Given this list of marker genes Rras, Rnd1, Rac1, Sema4d, Arhgef12, Plxnb1, Rock2, Arhgap35, Rhob, Met, Rhoa, Arhgef11, Rhoc (NCBI Gene Id 99594), Rock1, Erbb2, here is a description of the gene set: Sema4D in semaphorin signaling studied in species Mus musculus Mouse Gene Set: REACTOME_SEMA4D_IN_SEMAPHORIN_SIGNALING